The following is a description of a gene set: studied in species Mus musculus Any process that modulates the activity of the enzyme nitric-oxide synthase. Mouse Gene Set: GOBP_REGULATION_OF_NITRIC_OXIDE_SYNTHASE_ACTIVITY, and this is the list of marker genes: Tert, Htr2b, Fcer2a, Akt1, Dhfr, Lep, S100a1, Terf2, Nus1 (NCBI Gene Id 80282), Atp2b4, Esr1, Scarb1, Gch1, Cav1, Eng, Cav3, Nosip, Gla, Il1b